The following is a description of a gene set: Mouse Gene Set: WP_BIOGENIC_AMINE_SYNTHESIS studied in species Mus musculus Biogenic amine synthesis, and this is the list of marker genes: Dbh, Tph1, Pnmt, Chat, Ache, Hdc, Pah, Asmt, Gad2, Ddc, Aanat, Gad1, Maoa (monoamine oxidase A), Th, Comt